Given this list of marker genes GCLM, CBS, ME3, TNFRSF10A, SHMT2, SDS, ACSL1, ME2, ASNS, LAP3, GCLC, here is a description of the gene set: studied in species Homo sapiens Human Gene Set: MODULE_528 Genes in the cancer module 528.